The following is a description of a gene set: studied in species Mus musculus The directed movement of a pigment granule to a specific location. Mouse Gene Set: GOBP_ESTABLISHMENT_OF_PIGMENT_GRANULE_LOCALIZATION, and this is the list of marker genes: Rab17, Dctn2, Myo5a, Dctn1, Mreg, Map2k1, a, Rab11b, Rab1a, Bloc1s5, Myo7a, Bloc1s6, Shroom2, Rab27a (NCBI Gene Id 75673), Bloc1s3, Gpr143, Cdh3, Rab11a